Given this list of marker genes Zmiz1, Cipc, Ccdc71, Mrc2, Ccnt2, Tmem223, Snx19, Ypel2, Ccdc62, Rfesd, Zmat3, Rftn1, Smim13, Whamm, Ints4, Csn1s1, Zfp592, Tmem33, E130308A19Rik, Hbp1, Spdya, Sstr3, Zfp286, Rorc, Trmt9b, Nanp, Wdr26, Ppp4r1, Vps4b, Mthfr, Asb1, Pdha1, Etv5, here is a description of the gene set: from publication Chen Y, Wang X (PMID 31504780) Mouse Gene Set: MIR_7022_3P Genes predicted to be targets of miRBase v22 microRNA mmu_miR_7022_3p in miRDB v6.0 with MirTarget v4 prediction scores > 80 (high confidence targets). studied in species Mus musculus